Given this list of marker genes Mylk2, Kcnn4, Sptan1, Iqcf6, Myo1e, Map2, Cacna1c, Plcb3, Ryr3, Ttn, Camk1d, Marcks, Kcnn1, Ace, Ddx5, Adora2a, Iqcf4, Atp2b2, Cdk5rap2, Iqcb1, Snta1, Strn3, Ryr1, Cask, Trpv5, Add1, Atp5if1, Myh7, Myh3, Myo3a, Unc13a, Pcyt1a, Mapkapk3, Vamp2, Eef2k (NCBI Gene Id 97404), Adcy3, Rem1, Esrrg, Myo10, Pcnt, Add3, Scn2a, Scn3a, Kcnq3, Sphk1, Myo9b (NCBI Gene Id 17925), Camkk2, Adcy1, Orai1, Nos2, Invs, Atp2b1, Akap12, Myo1a, Camk4, Wfs1, Pla2g6, Ppp3cb, Ryr2, Nos1, Myh14, Sptbn1, Myo1f, Marcksl1, Myo7a, Mknk1 (NCBI Gene Id 80631), Map6d1, Camkv, Fas, Dapk2, Mapkapk5, Phkg1, Itpkc, Trpv6, Basp1, Sntb2, Kcnq1, Myh4, Phka1, Syt7, Nrgn, Camk2d, Phkb, Nos3, Mip, Fkbp8, Cnn3, Camsap3 (NCBI Gene Id 69697), Akap5, Camk2g, Aspm, Kcnq2, Cnga2, Spa17, Strn, Trpv1, Rrad, Camk1, Myh1, Myo1g, Mbp, Arpp21, Iqgap2, Add2, Pde1b, Smtnl1, Mylk, Plcb1, Pde1c, Mapkapk2, Camk2a, Cacna1s, Myo6, Myo1d, Ppp3cc, Sntb1, Aebp1, Cnn1, Map6, Camk1g, Unc13b, Camk2b (NCBI Gene Id 12323), Cth, Myo5b, Iqcg, Cacna1a, Grm4 (NCBI Gene Id 268934), Enkur, Myo5a, Scn5a, Grin1, Ceacam1, Iqschfp, Efcab9, Egfr (epidermal growth factor receptor), Iqcf1, Iqcf5, Grm7, Rit2, Myh9, Trpm4, Eef1a1, Slc24a4, Obscn, Myo1b, Iqgap1, Itpka (NCBI Gene Id 228550), Pate4, Trpv4, Rit1, Akt1, Ewsr1, Tjp1, Fbxl2, Ceacam2 (CEA cell adhesion molecule 2), Iqgap3, Ppp3ca, Kcnh1, Phkg2, Pik3r1, Camkk1, Cfap221, Ndufaf4, Kcnn3, Dapk1, Ngfr, Slc8a3 (solute carrier family 8 (sodium/calcium exchanger), member 3), Camsap1, Ubr4, Syt1, Pde1a, Tprg1l (NCBI Gene Id 67808), Pcp4, Myh6, Mknk2, Slc9a1, Cnn2, Kcnh5, Phka2, Edf1, Adcy8, Myh10, Myh11, Sry, Myo1c, Slc8a1, Slc8a2, Epb41, Pnck, Camsap2, Gap43, Spata17, Unc13c, Kcnn2, Esr1, Strn4, Rasgrf2, Atp2b4, here is a description of the gene set: Mouse Gene Set: GOMF_CALMODULIN_BINDING studied in species Mus musculus Binding to calmodulin, a calcium-binding protein with many roles, both in the calcium-bound and calcium-free states.